The following is a description of a gene set: Human Gene Set: GARCIA_TARGETS_OF_FLI1_AND_DAX1_UP The molecular hallmark of the Ewing's family of tumors is the presence of balanced chromosomal translocations, leading to the formation of chimerical transcription factors (that is, EWS/FLI1) that play a pivotal role in the pathogenesis of Ewing's tumors by deregulating gene expression. We have recently demonstrated that DAX1 (NR0B1), an orphan nuclear receptor that was not previously implicated in cancer, is induced by the EWS/FLI1 oncoprotein and is highly expressed in Ewing's tumors, suggesting that DAX1 is a biologically relevant target of EWS/FLI1-mediated oncogenesis. In this study we demonstrate that DAX1 is a direct transcriptional target of the EWS/FLI1 oncoprotein through its binding to a GGAA-rich region in the DAX1 promoter and show that DAX1 is a key player of EWS/FLI1-mediated oncogenesis. DAX1 silencing using an inducible model of RNA interference induces growth arrest in the A673 Ewing's cell line and severely impairs its capability to grow in semisolid medium and form tumors in immunodeficient mice. Gene expression profile analysis demonstrated that about 10% of the genes regulated by EWS/FLI1 in Ewing's cells are DAX1 targets, confirming the importance of DAX1 in Ewing's oncogenesis. Functional genomic analysis, validated by quantitative RT-PCR, showed that genes implicated in cell-cycle progression, such as CDK2, CDC6, MCM10 or SKP2 were similarly regulated by EWS/FLI1 and DAX1. These findings indicate that DAX1 is important in the pathogenesis of the Ewing's family of tumors, identify new functions for DAX1 as a cell-cycle progression regulator and open the possibility to new therapeutic approaches based on DAX1 function interference. species: Homo sapiens from publication García-Aragoncillo E, Carrillo J, Lalli E, Agra N, Gómez-López G, Pestaña A, Alonso J (PMID 18591936) Genes up-regulated in the A673 cells (Ewing sarcoma) after double knockdown of both FLI1 and DAX1 by RNAi., and this is the list of marker genes: KCNMB4, SMIM14, PJVK, SGSM2, FAM234A, CPT1B, NKX3-2, ZNF217, HMGCL (NCBI Gene Id 3155, 3-hydroxy-3-methylglutaryl-CoA lyase), NCKAP5, KLHDC8B, STAT2, LGALS1, ADCK5, KCP, KDELR3, ATP7B, UBE2L6, INPPL1, SNX14, GNPTG, NEIL1, HLA-E, SVIL, MAP3K1, PGAP1, MYO6, STIM1, MAGED4B (MAGE family member D4B), PBXIP1, C5orf15, RASA4, CUL7, SYNGR1, PLIN3, LRP10, IGFBP5, LMBR1L, ZFP90, NBAS, FNDC4, ANKRA2, PTGES3, SEMA6A, CIRBP, SLC26A11 (NCBI Gene Id 65011), WDR19, IFT140, RFNG, FKBP14